Given this list of marker genes MAGT1, EPG5, LEP, LEPR, CARMIL2, CD40LG, RNU4ATAC, CASP8, TGFB1, here is a description of the gene set: Any abnormality in the activation of T cells, i.e. the change in morphology and behavior of a mature or immature T cell resulting from exposure to a mitogen, cytokine, chemokine, cellular ligand, or an antigen for which it is specific. species: Homo sapiens Abnormal T cell activation Human Gene Set: HP_ABNORMAL_T_CELL_ACTIVATION